The following is a description of a gene set: studied in species Homo sapiens Human Gene Set: GOBP_MALE_SEX_DIFFERENTIATION The establishment of the sex of a male organism by physical differentiation., and this is the list of marker genes: ABCB1, RRM1, CRKL, HMGA2, ASB1, NCOA4, PATZ1, HOXA13, DHCR24, AR, WNT5A, SOX9, WDR48, ADAM18, GATA4, FER, NHLH2, RBP4, PRPS1L1, CBL, BCL2L2, MCIDAS, ATN1 (NCBI Gene Id 1822), REN, INHBB (inhibin subunit beta B), SMAD4, KITLG, LGR4, NR5A1, ASPM, EIF2S2, SCX, TEX19, ADAM32, ADAM21, HMGB2, DNAAF11, ADAM15 (ADAM metallopeptidase domain 15), NASP, SAFB2, ADAM2, DMRT3, FKBP4, CTNNA1, LHCGR, SOX15, GFRA1, HOXD13, TGFB2, MIR455, RXFP2, STAT5A, BOK, SCAPER, RARA, AGO4, BCL2L11, ARID4A, TEX11, LHB, ACVR2A, GMNC, TGFBR1, ODAD3, ARID5B, ADGRG1, FGF8, HOXA11, FNDC3A, ARID4B, DHH, RAB13, HSD17B3, TBC1D20, BAX, PLEKHA1, ADAM20, PDGFRA, MAMLD1, PRDX4, HOXA9 (homeobox A9), SFRP1, NR0B1, SRD5A1, WNT2B, SOX8, LHX9, NKX2-1, LHFPL2, TESC, RBMY1B, TCF21, NR5A2, TBX3, ESR1, SYCP2, SIX4, INHBA, CD2AP, KIF18A, RHOBTB3, NUP210L, GATA3, SPATA2, MSH2, SMAD5, FGF9, AMHR2, PRKACG, BMP6, H3-3B, WNT4, WT1, FSHR, HOXA10, GATA6 (GATA binding protein 6), ATRX (NCBI Gene Id 6475), ZFP42, BCL2, H3-3A, CCNO, FGF10, GREB1L, FSHB, AKR1C3, KIT, DNAAF3, CCND1, DMRT1, BMPR1A, NUPR1, TFAP2C, BRIP1, GATA1, MMP14, RNF38, YBX3, SFRP2, FLNA, MEA1, CSDE1, KLHL10, UBB, INHA, UTF1, BCL2L1, STAT5B, AMH, NKX3-1, BIK, WNT9B, BMP5, TLR9, SGPL1, INSR, ADAM30, LRP2, SRD5A2, NTRK1, NCOA1, HSD17B4, ACE, CTNNB1, ZFPM2, CITED2, SRY, REC8, ING2, ERCC1, FANCA, TLR5, SHH, ADAM29, TMF1, DHX37 (NCBI Gene Id 84742), TLR3, CSMD1